The following is a description of a gene set: Catalysis of the reaction: 1-phosphatidyl-1D-myo-inositol 3,5-bisphosphate + H2O = 1-phosphatidyl-1D-myo-inositol phosphate + phosphate. Human Gene Set: GOMF_PHOSPHATIDYLINOSITOL_3_5_BISPHOSPHATE_PHOSPHATASE_ACTIVITY species: Homo sapiens, and this is the list of marker genes: MTMR3, INPP5E (NCBI Gene Id 56623), MTMR14, PIKFYVE, OCRL, PTPRQ, MTMR1, SYNJ1, MTMR8, MTM1, MTMR6, FIG4, SYNJ2, MTMR4, MTMR7, MTMR2 (NCBI Gene Id 8898)